The following is a description of a gene set: This event has been computationally inferred from an event that has been demonstrated in another species.<p>The inference is based on the homology mapping from PANTHER. Briefly, reactions for which all involved PhysicalEntities (in input, output and catalyst) have a mapped orthologue/paralogue (for complexes at least 75% of components must have a mapping) are inferred to the other species. electronically inferred by orthology from the curated human pathway Reactome Pathway: Transcriptional and post-translational regulation of MITF-M expression and activity part of: MITF-M-regulated melanocyte development species: Mus musculus, and this is the list of marker genes: Kars1, Eef1e1, Hint1, Ep300, Sox10, Mitf, Kit, Sirt1, Qars1, Kitl, Mapk3, Tnfsf11, Wnt3a, Xpo1, Aimp2, Sumo1 (small ubiquitin-like modifier 1)